Given this list of marker genes ARR3, OPN3, ARL3, SDCCAG8, RPGRIP1, NPHP1, OPN5, PKD2L1, DRD5 (NCBI Gene Id 7883), SPTBN5, WHRN, SEPTIN7, SAG, PCDHB15, TUBG1, TTC8, PDE6H, PCDHB13, CFAP410, PTGS1, CCDC66, SEPTIN2, PKD1L1, MAK, KIFAP3, TSGA10IP, GLIS2, MERTK, PIP4K2A, RAB8A, KIAA1549, CNGB3, GNAT1, GUCA1B, WDR19, PDC, SEPTIN9 (septin 9), GNB1, VCAN, TTLL6, MKKS, TTLL4, CRB1, STX3, IFT52, IQCB1, PRPH2, MAGI2, RPGR, CEP290, RGS9BP, CFAP96, IFT20, PCARE, RPGRIP1L (RPGRIP1 like), KNCN, OPN1MW2, BBS4, POC5, ENKD1 (NCBI Gene Id 84080), GALR3, SMO, STRC, CETN2, CNGB1, OCRL, CERKL, PDE6A, RSPH9, EYS, PKD2, IFT80, RCVRN, GUCA1A, LYAR, USH2A, CDH23, DRD2, PDE6G, GNAT2 (G protein subunit alpha transducin 2), PEX6 (NCBI Gene Id 5190), OPN1SW, PHLPP2, LCA5, PKHD1, RAC1, TULP3, GUCY2D, CDC14A, DCDC2, CEP250, INHA, GRK1, IFT88, KIF17, CNGA4, OPN1MW, AHI1, IFTAP, ROM1, ARL13B, CEP89, RP1, RHO, GRK4, TOPORS, STRCP1 (NCBI Gene Id 554225), GUCY2F, CNGA2, CDHR1, SHANK2, GUCA1C, CIB2, SSTR3, FAM161A, IFT57, NXNL1, IFT122, SLC24A4, GNA11, TULP1, PCM1, DRD1 (dopamine receptor D1), IFT140, CFAP69, ATP1A4, BSG, IMPG1, DYNLL2, RP1L1, ERICH3, CNGA1, MYO7A, MAP1B, ABCA4, RAB27A, CETN3, NPY2R, PCDH15, CETN1, CACNA1F, RAB37, OPN1MW3, PPEF2, DHRS3, TMEM237, TBCC, USH1C, GUCA1ANB-GUCA1A, GPR83 (G protein-coupled receptor 83), PROM1, ARL13A, NPHP4, PHYH, MCHR1, RD3, HYLS1, C1orf115, PDE6B, SPATA7, OPN1LW, GRK7, GNGT1, PRCD, GNAQ, NAPEPLD, OPN4, GRXCR1, USH1G, ELMOD3, BBS7, MYRIP, here is a description of the gene set: species: Homo sapiens Human Gene Set: GOCC_NON_MOTILE_CILIUM A cilium which may have a variable array of axonemal microtubules but does not contain molecular motors.